The following is a description of a gene set: Comprehensive identification of all functional elements encoded in the human genome is a fundamental need in biomedical research. Here, we present a comparative analysis of the human, mouse, rat and dog genomes to create a systematic catalogue of common regulatory motifs in promoters and 3' untranslated regions (3' UTRs). The promoter analysis yields 174 candidate motifs, including most previously known transcription-factor binding sites and 105 new motifs. The 3'-UTR analysis yields 106 motifs likely to be involved in post-transcriptional regulation. Nearly one-half are associated with microRNAs (miRNAs), leading to the discovery of many new miRNA genes and their likely target genes. Our results suggest that previous estimates of the number of human miRNA genes were low, and that miRNAs regulate at least 20% of human genes. The overall results provide a systematic view of gene regulation in the human, which will be refined as additional mammalian genomes become available. Genes having at least one occurrence of the highly conserved motif M53 RYTGCNNRGNAAC in the regions spanning 4 kb centered on their transcription starting sites. This matches the MIF transcription factor binding site V$MIF1_01 (v7.4 TRANSFAC). from publication Xie X, Lu J, Kulbokas EJ, Golub TR, Mootha V, Lindblad-Toh K, Lander ES, Kellis M (PMID 15735639) Human Gene Set: RYTGCNNRGNAAC_MIF1_01 species: Homo sapiens, and this is the list of marker genes: BCL2L1, GRIK5 (glutamate ionotropic receptor kainate type subunit 5), GBF1, SELENOF, DNAI1, DRP2, BBS2 (Bardet-Biedl syndrome 2), CEP83, CPEB2, FAM219A, ELAPOR1, TTC12, GPC3, HMGCS1, ODAD3, SPPL2B, EFTUD2, ENKD1, KCNT2, PTCH1, MAPK10, CCDC103, AP1M1, MAGED1, VEGFA, PIK3IP1, CACNA2D3, LSM7, LHX6, DNAH7, ITGB8, SPA17, FGR, GRM3, NAA60, SMC1B, E2F5, SALL2, BMP6, C6orf62, STK36, RAC1, STMN4, CCDC24 (coiled-coil domain containing 24), RNF25, CCDC60, RNF138, BTG4, CYTH2, NAA20, EFNB3, NRGN, ERRFI1, CX3CL1, KIF17, WDR17, FILIP1, CCDC126, SIAE, C10orf53, PDZD4, PDCL2, HOATZ, AZI2, FUZ, MDH1B, KCNK10, DPAGT1, WARS2, RIBC2, BOP1, HM13, FASTKD2, TEKT4 (NCBI Gene Id 150483), NCOA5, ZNF593, ADAMTS17, PRKCSH, PAK6, FHIP1B, HS2ST1, UBB, MED25, SIX1, LINC00649, HSF1, KCNRG, PPME1, CEP164, MAP9